The following is a description of a gene set: Increased aperture of the nostril. Enlarged naris Human Gene Set: HP_ENLARGED_NARIS studied in species Homo sapiens, and this is the list of marker genes: NALCN (NCBI Gene Id 93074), NAA10, MKS1, ZFX, DDR2 (NCBI Gene Id 4921), NSD1, UNC80